Given this list of marker genes Krtdap, Twsg1, H2-K1, Asb6, Sorbs1, Tmem106c, Tspo, Rab40c, Myl1 (myosin, light polypeptide 1), Zfr, Sort1, Etfdh, Mapre2, Abcc5, Rgcc, Pum1, Lman1, Avpr1a, Fermt3, Rarres2 (NCBI Gene Id 71660), Pkdrej, Mndal, Idh3g, Serpinb9c, Map1b, Tcap, Lxn, Chek2, Arpp19, Art3 (ADP-ribosyltransferase 3), Ikzf1, Scd2, Il18r1 (interleukin 18 receptor 1), Egln3, Cyp4b1, Nubp1, Tgfbi, Pea15a, Cdc42bpa, Fah, Sod3, Zfp37, Il33, Sprr2d, Lum, Dap, Mef2a, Pex13, Slurp1, Gna13, Klk1b27, Gm57857, Ctdsp2, Prelp, Hbp1, Slc22a2, Dtx3, Zc3h11a, Ndrg1, Ncf1, Serpinb2, Gzmb, Pcx, Trib1, Asb7, Krt12, Ifi205, Clcf1, Akr1c18, Ide, Zfp521, Immt, Cfl2, Lypd8l, Has3, Tgfbr3, Lgals3bp, Tcim, Rsad2 (radical S-adenosyl methionine domain containing 2), Pdgfa, Lpl, Ddx3y, Atp2a1, Nsmaf, Itih5, Cox6a1, Aldh1a7, Tnfsf14, Pdlim5, Atxn7l3b, Fuca1, Msr1, Gm13394, Pfkfb3, Cdh5, Ube2h, Dusp1, Mob1a, Btc, Immp2l, Cars1, Ms4a6b, Lasp1, H1f2, Clca3a1, Smad5, S100a10, Skp2, Cfd, Myo5b, Slc6a4, Ap3m1, Lrrc8c, Gpd1 (glycerol-3-phosphate dehydrogenase 1 (soluble)), Tmed9, Eif4h, Pecam1, Pdk4, Zfp106, Esd (esterase D/formylglutathione hydrolase), Tmcc2, Capzb, Hdlbp, Vmn1r49 (NCBI Gene Id 24112), Fbln1, Laptm4a, Fads2, Hoxb2, Pck1, Ly6d, Hsd17b11, Ucp3, Man1a2, Plac1, Ccl20, Qpct, Arxes1, Epas1, Ptpn14, Trp53, Mcm6, Timp1 (tissue inhibitor of metalloproteinase 1), Chpt1, Psap, Lrg1, Klhl13, Abcb8 (NCBI Gene Id 74610), Dusp22, Snrpn, Eif3a, Adipoq, Pbk, Hoxb6, Rgs4, Acsl1, Grb10, Slc11a2, Tmem234, Zfp260, Fos, Il6st, Sprr2a1, Cldn11, Acox1, Atpaf2, Ahr, Ptgs2, Nr4a1, Ifi27l2a, Ly6a, Chchd10, Spon2, Swsap1, Prkce, Rab31, Hbs1l, Tmem45a, Xrn2, Ephx2, Slc26a7, Gosr2, Ceacam1, Nedd4, Vmn1r46 (NCBI Gene Id 113856), Prkd3 (protein kinase D3), Bzw1, Pink1, Ropn1l, Sgpl1, Pigo, Lancl2, Sar1a, Adh1, Stom, Krt16, Gsta2, Usf1, Hnrnpll (NCBI Gene Id 72692), Litaf, Mtx1, Lancl1, Sgcg, Cd36, Spin1, Clns1a, Cenpb, Etfrf1, Ptbp3 (NCBI Gene Id 99962), 1810037I17Rik, Me1, Hnf4g, Mfap5, Bad, Babam2, Arl5a, Krt77, Lpin1, Trf, Nnat, Fam107b, Ms4a6d, Bmp1, Rxra, Havcr2, Tnfaip6, Sirpa, Bicd2, Pitx2, Retn, Cxcl12, Sigmar1, Dnpep, Kif20a, Rfc1, Fgl2, Washc2, Ctf1 (NCBI Gene Id 13019), Inppl1, Tmem106b, Arcn1, Klb, Car4, Rbms1, Msra, Prdx1, Bid, Fam162a, Tbk1, Ccnd2, Pip4k2a, Capn6, Pira1, Pnpla2, Pilra, Pttg1, Cidec, Spag5, 9530068E07Rik, Rnf114, Ctbs, Git2, Lipa, Hcar2, Opa1, Car3, Serinc3, Eml5, Add3, S100a8, Slc25a13, H2-Aa, Bnip3, Saa3, Cldn15, Ak3, Tmem191, Gstz1, Camk4, Pdgfc, Tm6sf1, Dram2, Wdr45, Ccn3, Ndufs4, Cpd, Hmga2, Fech, Star, Snrnp27, Gbp2, Sec61a2, Ilf3, Cttn, Ncoa4, Ereg, Atp2a2, Hipk3, Hspa9, Cpa3, Agtr2, Rpa1, Klra4, Ctsb, Zic3, Hdc, Rad21, Hadh, Nsf, Bcap31 (B cell receptor associated protein 31), Lcp1, Ier3, Serpinb3c, Csrp3, Cyp11a1, Prmt6, Six2, S100b, Lep, Txnip, Dvl1, Marchf2, Apoc2, Nap1l1 (nucleosome assembly protein 1-like 1), Fgfbp1, Nr3c1 (nuclear receptor subfamily 3, group C, member 1), Hmgcs2, Tfpi2, Mst1r (macrophage stimulating 1 receptor (c-met-related tyrosine kinase)), Ip6k1, Fscn1, Igf2, Mrap, Arxes2, Thbs1, Tcf12, Cmtr1, Tpsb2, Trp63, Rnf14, Vapb, Bphl, Aqp1, Lims1, Nabp1, Recql, Zfp445, Rbbp4, Kdm8, Sptbn1, Calcoco2, Ucp1, Plgrkt, Ubap2l, Fbxw8, Tyrobp, Qsox1, Map2, Cd59a, Cab39l, Amd-ps1, Arrdc4, Asph, Serpina12, Itgav, Fabp1, Casq1, Papola, Tcea1, Zdhhc5, Ltc4s, Atf3, Get3, Ints12, Cp, Ctla2a (cytotoxic T lymphocyte-associated protein 2 alpha), Tmem109, Lipe, Ushbp1, Pcca, Atf2, Srpk1, Cav3, Rptn, Mrc2, Akr1b8, Coa5, Emp2, Slc39a3, Ptgfr, Itm2a, Dgcr2, Ncf2, Serpinf1, D17H6S56E-5, Tpp2, Uty, Tshr, Gpsm1, Ptprg, Prkar1b, Thrsp, Cdkn1a, Tfrc, Psmf1, Acad8, Ndst2, Septin8, Trbc1, Sprr1b, Fnta, Rab2b, St3gal2, Pmepa1, Uck1, Sdcbp2, Fut2, H2-D1, Slc14a1, Brat1, Sox4 (SRY (sex determining region Y)-box 4), Ubb (ubiquitin B), Sult2b1, Neu2, B2m, Slc4a10, Bag4, Dram1, Rpgrip1, Ube2d3, Rabgap1, Vps25, Ifi203, Scube1, Srek1ip1, Agpat5, Prkacb, Actb, Slc48a1, Itga9, Dnajb1, Cer1, Ldhc (NCBI Gene Id 16833), Lce1f (late cornified envelope 1F), Actn3, Zfp410, Tubgcp2, Slc25a10, Arl8b, Usp34, Aco1, Prr13, Aif1l, Npy4r, Serp1, Parp3, Nit2, Iigp1, Pitpnb, Myl4, Esyt3, Klf3, Cenpv, Wdr48, Gnas, Osr2, Ginm1, Pcsk6, Eloc (NCBI Gene Id 98484), Pon3, Egfr (epidermal growth factor receptor), Nadk, Alox5ap, Zbed3, Cav2, Cfap97, Slc25a48, Ighg2b, Celf2, Cat, Fth1 (ferritin heavy polypeptide 1), Slc1a5, Ap2a1, Kif11, Eps8l1, Lmnb1, Hoxa9, Rimoc1, ENSMUSG00000144058, Csf1r, Apoa4, Selenof, Caprin1, Cd163, Mrpl3, Nlk (NCBI Gene Id 18099), Lbp, Xdh, Alas1, Ddx3x, Car13, Cldn5, Rxylt1 (ribitol xylosyltransferase 1), Cd74 (NCBI Gene Id 16149), Virma, Clec4e, Srgn, Nt5e, Chd9, Ift46, Dhx40, Il36g, Il1r2, Stard4, Cep85, Dnm2, Ppp3ca, Casp6, Serpinb1a, Sh3kbp1, Hacd3, Cd44 (NCBI Gene Id 99339), Jak1, Cacna2d1, C1qb, Ackr1, Lce1a2, Ptprf, Fhl2, Fgfr2, Ykt6, Il2rg, Gzmg, Defb7, Chst1, Tmem222, Krt6b, Morc3, Pld1, Cpt1b, Suco (SUN domain containing ossification factor), Txndc12, Nudt7, Npm3, Tbrg4, Arhgap1, Angptl2, Glo1 (glyoxalase 1), Eif4g1, Nsun4, Pdpk1, ENSMUSG00000139502, Fabp4, Sppl2b, Rrm1, Ccnl2, Acyp1, Rnf41, Plin4, Tuba4a, Dctn4, Qki, Plek2, Tgfbr2, Fbp2, Ckm, Tm6sf2, Wars1, Ccl9, Hspb7, Acbd3, Ap2b1, Tcf7 (transcription factor 7, T cell specific), Tes3-ps, Mr1, Rtn4 (NCBI Gene Id 68585), Chrnd, Tgfb2, Dpysl3, Eri2, Trex2, Gja1, Zfp330, Ctr9, Bcl2l13, Slc25a30, Agk, Lyz2 (NCBI Gene Id 17107), Hcfc1, BC028528 (cDNA sequence BC028528), Art1, Cnot4, Snx17, Scoc, Gna12, Acta1, Tslp, Uap1, Slc2a4, Ghr, Bbox1, Slc22a21, Itga4, Tspan3, Pcyt1a, Smoc2, Kras, Il36a, Uqcrb, Cma1, Racgap1, Mir214, Glrx, Fcgr2b (Fc receptor, IgG, low affinity IIb), Sprr2h, Il36rn, Hif3a, Ranbp9, Ccn1, Enpp3, Wee1, Triap1, Tpsab1, Lgals9, Psme4, Cldn10, Gsk3b, Rbp7, Slc35a3, Pou2f3, Lgals1, Add1, Prps1, Ptprz1, Sncg, Cysrt1, Acaa2, Pla2g2f, Col4a5, Actrt2, Trp53inp2, Os9, Lmbr1, Pip5k1a, here is a description of the gene set: from publication Martínez-Cruz AB, Santos M, Lara MF, Segrelles C, Ruiz S, Moral M, Lorz C, García-Escudero R, Paramio JM (PMID 18245467) Genes up-regulated in mice with skin specific double knockout of both RB1 and TP53 by Cre-lox. Squamous cell carcinomas (SCC) represent the most aggressive type of nonmelanoma skin cancer. Although little is known about the causal alterations of SCCs, in organ-transplanted patients the E7 and E6 oncogenes of human papillomavirus, targeting the p53- and pRb-dependent pathways, have been widely involved. Here, we report the functional consequences of the simultaneous elimination of Trp53 and retinoblastoma (Rb) genes in epidermis using Cre-loxP system. Loss of p53, but not pRb, produces spontaneous tumor development, indicating that p53 is the predominant tumor suppressor acting in mouse epidermis. Although the simultaneous inactivation of pRb and p53 does not aggravate the phenotype observed in Rb-deficient epidermis in terms of proliferation and/or differentiation, spontaneous SCC development is severely accelerated in doubly deficient mice. The tumors are aggressive and undifferentiated and display a hair follicle origin. Detailed analysis indicates that the acceleration is mediated by premature activation of the epidermal growth factor receptor/Akt pathway, resulting in increased proliferation in normal and dysplastic hair follicles and augmented tumor angiogenesis. The molecular characteristics of this model provide valuable tools to understand epidermal tumor formation and may ultimately contribute to the development of therapies for the treatment of aggressive squamous cancer. studied in species Mus musculus Mouse Gene Set: MARTINEZ_RB1_AND_TP53_TARGETS_UP